Given this list of marker genes STXBP1, NAALADL1, MST1, ARHGAP4, AZI2, SIX3, HGF, PRODH, TMEM87A, VCL, RAB5B, SKAP2, PTCH1, GALNT3, MFNG, FGF13, AFF2, P4HB, LAMC1, PCBP3, ANXA8, MEG3, NKX3-2, GABRE, LGALS9, PTGER1, CST7, CALR (NCBI Gene Id 811), NRIP1, MXRA7 (NCBI Gene Id 54588), here is a description of the gene set: Top genes from cluster 12 of acute myeloid leukemia (AML) expression profile; 89% of the samples are FAB M3 subtype, 95% bear the t(15;17) translocation, all have the PML-RARA fusion; indicate good survival. from publication Valk PJ, Verhaak RG, Beijen MA, Erpelinck CA, Barjesteh van Waalwijk van Doorn-Khosrovani S, Boer JM, Beverloo HB, Moorhouse MJ, van der Spek PJ, Löwenberg B, Delwel R (PMID 15084694) Human Gene Set: VALK_AML_CLUSTER_12 studied in species Homo sapiens BACKGROUND: In patients with acute myeloid leukemia (AML) a combination of methods must be used to classify the disease, make therapeutic decisions, and determine the prognosis. However, this combined approach provides correct therapeutic and prognostic information in only 50 percent of cases. METHODS: We determined the gene-expression profiles in samples of peripheral blood or bone marrow from 285 patients with AML using Affymetrix U133A GeneChips containing approximately 13,000 unique genes or expression-signature tags. Data analyses were carried out with Omniviz, significance analysis of microarrays, and prediction analysis of microarrays software. Statistical analyses were performed to determine the prognostic significance of cases of AML with specific molecular signatures. RESULTS: Unsupervised cluster analyses identified 16 groups of patients with AML on the basis of molecular signatures. We identified the genes that defined these clusters and determined the minimal numbers of genes needed to identify prognostically important clusters with a high degree of accuracy. The clustering was driven by the presence of chromosomal lesions (e.g., t(8;21), t(15;17), and inv(16)), particular genetic mutations (CEBPA), and abnormal oncogene expression (EVI1). We identified several novel clusters, some consisting of specimens with normal karyotypes. A unique cluster with a distinctive gene-expression signature included cases of AML with a poor treatment outcome. CONCLUSIONS: Gene-expression profiling allows a comprehensive classification of AML that includes previously identified genetically defined subgroups and a novel cluster with an adverse prognosis.